The following is a description of a gene set: Human Gene Set: GOMF_MANNOSYL_OLIGOSACCHARIDE_MANNOSIDASE_ACTIVITY species: Homo sapiens Catalysis of the hydrolysis of the terminal alpha-D-mannose residues in oligo-mannose oligosaccharides., and this is the list of marker genes: EDEM3, EDEM2 (ER degradation enhancing alpha-mannosidase like protein 2), EDEM1, MAN2A2, MAN2A1, MAN1B1, MAN1C1, MAN1A2, MAN1A1